Given this list of marker genes LIMS2, C9orf72, PSAT1, STAMBP, NAA60, SLC19A3, KCNQ2, STXBP1, CHCHD10, POLR3K (RNA polymerase III subunit K), TNFRSF11A, GSS, MRM2, LMX1B, MRAP, ARFGEF2, POLG, SQSTM1, COA8, NEK1, PRPS1, APOE, SLC1A3, UGP2, LIPT2, TNR, PHACTR1, MT-ATP6, AGTPBP1, NAXE, HSD17B10, EXOSC8, EIF2S3, L2HGDH, PNP, PDHX, EARS2, SLC25A10, RNU7-1, GAD1, SNAPC4, SMC1A, CARS2, SLC35A2, SARDH, MOCS1, GBE1, REEP1, COL4A1, GJA1 (gap junction protein alpha 1), IFIH1, PSEN1, PPOX, ARX, ALS2, AHDC1, PRDM8, ALG3, HINT1, TBK1, GM2A, PSAP, FBLN1, LIPT1, NEXMIF, ADAR, SDHB, ATP1A3, TMEM222, NMNAT1, PLP1, DYM, UCHL1, SLC18A2, TBCE, VCP, FA2H, ATP6V1A, SOX4, PLA2G6, NUP54, TARDBP (TAR DNA binding protein), SOD1, AIFM1 (NCBI Gene Id 9131), AASS, LRP4, KCNJ6, TRAPPC4, MFSD2A, FUS, ERLIN2, FAR1, LMNB1, GUF1, SDHA (NCBI Gene Id 6389), RERE, CACNA1A, GALC, SLC1A2, AFF3, ATP5F1A, BSCL2, TACO1, PRUNE1, SDHAF1, AUH, EIF4A2, ABCD1, WDR62, NDUFS3, NUP62, TUBB2B, SDHD, LYRM7, CA2, ATP1A2, ESAM, PAFAH1B1, NFU1, here is a description of the gene set: Human Gene Set: HP_TETRAPARESIS Tetraparesis studied in species Homo sapiens Weakness of all four limbs.